Given this list of marker genes TGFBR2, ZFYVE9, FKBP1A, TGFB1, SMAD3, TGFBR1, SMAD4, SMAD2, here is a description of the gene set: Signaling by TGF-beta Receptor Complex in Cancer Human Gene Set: REACTOME_SIGNALING_BY_TGF_BETA_RECEPTOR_COMPLEX_IN_CANCER studied in species Homo sapiens